The following is a description of a gene set: Genes having at least one occurence of the motif GTGACTT in their 3' untranslated region. The motif represents putative target (that is, seed match) of human mature miRNA hsa-miR-224 (v7.1 miRBase). species: Homo sapiens Human Gene Set: GTGACTT_MIR224, and this is the list of marker genes: PLPP3, DDX3X, CERKL, PAXBP1, PPP2R1B, GGNBP2, GCH1, ACACA, NIT1, ZDHHC20, HYCC2, GLRA2, DIO1, MBNL1, UBE2D3, MAF1, NUAK1, ACSL4, CDK9, NR4A2, PPEF2, AZIN1, MGAT4B, AMOTL2, SMAD5, ZNF655, ARHGAP21, BAZ2A, SMAD4, SLMAP, C19orf47, MAPK14, KLK15, KDM3A, SAMTOR, MAF, CYRIB (CYFIP related Rac1 interactor B), SMARCAD1, IL1RN, EPC2, HOXD10, SYP, NOTUM, UBQLN2 (ubiquilin 2), SEPTIN3, ITGA3, RBM12B, TMEM117, KIF23, GTSF1, RND3, EGR2, SUFU, FOSB, PLAG1, MAFG, ATP1B3, H3-5, NUP153, OTUB2, ATF2, NPAS4, SLC12A5, AMMECR1, QKI, KCTD12, HOXA5, WSB1, MYLIP, HOXA7, KCNMA1, H3-3B, ARHGEF12, DR1, SLC4A4, COL7A1, STMN1, IGF2R, NCOA6, UBQLN1, DNM1, ID3, ITM2B (integral membrane protein 2B), PUM2, CBX7, YOD1, ZFHX4, MARF1, CDC42, HNRNPU, HES5, POLR1D, UBE2NL, EYA4, MBNL2, TCERG1, TMEM9B, TRA2B, HABP2, KDM2A, SDC4, MED13L, SP7, AMIGO2 (adhesion molecule with Ig like domain 2), CIT, BRPF3, PDLIM7, CGGBP1, FNDC5, AFF3, ZNF207, CASC3, SERTAD2, GPN1, AP2M1, APBA2, EFNA3 (NCBI Gene Id 1944), USP37, ENAH, GTPBP2, CREB5, DDX3Y, FOXN3, CCDC178, PTX3, FTH1, MAP1B, HMGCR, ITSN1, GGA3, RBBP5, LYPD6 (NCBI Gene Id 130574), PRP4K, RERE, WTAP, CPNE8, CREBRF, ZNF423, PIEZO2, TRIM9, CAST, ARK2N, KBTBD8, PDGFRA, WDR26, CPEB2, PHLPP1, NR4A1 (nuclear receptor subfamily 4 group A member 1), DPYSL2, RNF38, PKDCC, PRR3, SPPL3, RUNX2, API5, GPC4, SYNGR1